The following is a description of a gene set: Reactome Pathway: Activated NTRK2 signals through FYN In mouse brain, Fyn activation downstream of Bdnf-induced Ntrk2 (TrkB) signaling results in increased protein levels of AMPA receptor subunits Gria2 (GluR2), Gria3 (GluR3) and Gria1 (GluR1) without change in mRNA levels.<p>BDNF-mediated activation of NTRK2 increases phosphorylation of voltage gated sodium channels by FYN, resulting in decrease of sodium currents.<p>FYN activation downstream of NTRK2 is implicated in olygodendrocyte myelination and contributes to BDNF-induced activation of ERK1/2 (MAPK3/1) through an unknown mechanism.<p>Besides acting downstream of NTRK2, FYN and other SRC kinases, activated by other receptors such as GPCRs, may phosphorylate NTRK2 and enhance its catalytic activity. part of: Signaling by NTRK2 (TRKB) species: Homo sapiens, and this is the list of marker genes: FYN, DOCK3, SRC, RAC1, GRIN2B, BDNF, NTRK2